The following is a description of a gene set: studied in species Homo sapiens part of: Peptide ligand-binding receptors Relaxins are part of a family of peptide hormones that diverged from insulin in early vertebrate evolution to form the insulin-like peptides and relaxins, now often referred to as the relaxin peptide family. All are heterodimers; both chains are cleaved from a common propeptide and cross-linked by 2 disulphide bonds. Humans have 3 true relaxins encoded by 3 related genes, plus several more distantly related insulin-like peptide genes. Non-primates have 2 relaxin genes. The major circulating form of relaxin in humans is relaxin-2, equivalent to relaxin-1 in non-primates. Relaxin-3 is very highly conserved. Little is known about human relaxin-1; several of the insulin-like peptides have no known receptor or function. <br> There are 4 human G-protein coupled receptors for relaxin family peptides. Relaxin receptor 1 (RXFP1) and relaxin receptor 2 (RXFP2) are also known as LGR7 and LGR8 respectively, members of the LRR-containing G protein-coupled receptors (LGRs). Relaxin-3 receptor 1 (RXFP3) and Relaxin-3 receptor 2 (RXFP4) are unrelated, having more homology with small peptide receptors such as the somatostatin receptors. Reactome Pathway: Relaxin receptors, and this is the list of marker genes: RXFP2, RLN3, INSL3 (insulin like 3), RXFP3, RXFP1, RXFP4, RLN2, INSL5